The following is a description of a gene set: Progressive pulmonary function impairment Human Gene Set: HP_PROGRESSIVE_PULMONARY_FUNCTION_IMPAIRMENT studied in species Homo sapiens, and this is the list of marker genes: TERT (telomerase reverse transcriptase), NF2, TRAF7, SLC34A2, SUFU, SMARCE1 (SWI/SNF related, matrix associated, actin dependent regulator of chromatin, subfamily e, member 1), PIK3CA, SMO (NCBI Gene Id 6608), BAP1, SMARCB1, SMPD1, AKT1, PDGFB